Given this list of marker genes Pcsk5, Ngf, here is a description of the gene set: Reactome Pathway: Expression and Processing of Neurotrophins This event has been computationally inferred from an event that has been demonstrated in another species.<p>The inference is based on the homology mapping from PANTHER. Briefly, reactions for which all involved PhysicalEntities (in input, output and catalyst) have a mapped orthologue/paralogue (for complexes at least 75% of components must have a mapping) are inferred to the other species. studied in species Mus musculus electronically inferred by orthology from the curated human pathway part of: Signaling by NTRKs